Given this list of marker genes Jak1, Ccl5, Klf6, Klf2, Gpx4, Fos, S100a10, Ets1, Jun, Epsti1, here is a description of the gene set: Mouse Gene Set: CUI_NK_CELL_IFNG_RESPONSE_DN Genes negatively differentially expressed in cell type: NK cell upon treatment with cytokine: IFN-γ in mouse lymph nodes in vivo. species: Mus musculus Cytokines mediate cell-cell communication in the immune system and represent important therapeutic targets. A myriad of studies have highlighted their central role in immune function, yet we lack a global view of the cellular responses of each immune cell type to each cytokine. To address this gap, the authors created the Immune Dictionary, a compendium of single-cell transcriptomic profiles of more than 17 immune cell types in response to each of 86 cytokines (>1,400 cytokine-cell type combinations) in mouse lymph nodes in vivo. A cytokine-centric view of the dictionary revealed that most cytokines induce highly cell-type-specific responses. For example, the inflammatory cytokine interleukin-1β induces distinct gene programmes in almost every cell type. A cell-type-centric view of the dictionary identified more than 66 cytokine-driven cellular polarization states across immune cell types, including previously uncharacterized states such as an interleukin-18-induced polyfunctional natural killer cell state. from publication Cui A, Huang T, Li S, Ma A, Pérez JL, Sander C, Keskin DB, Wu CJ, Fraenkel E, Hacohen N (PMID 38057668)